The following is a description of a gene set: Mouse Gene Set: GOBP_EPOXYGENASE_P450_PATHWAY studied in species Mus musculus The chemical reactions and pathways by which arachidonic acid is converted to other compounds including epoxyeicosatrienoic acids and dihydroxyeicosatrienoic acids., and this is the list of marker genes: Cyp2b10, Cyp2j5, Cyp2a22, Cyp2a12 (cytochrome P450, family 2, subfamily a, polypeptide 12), Cyp2g1, Cyp2b9, Cyp2t4, Cyp4a31, Cyp2j8, Cyp2j6, Cyp2b13, Cyp2c23, Cyp2e1, Cyp4a32 (NCBI Gene Id 674313), Cyp2s1, Cyp2j7, Cyp4a10, Cyp2j11, Cyp2j9, Cyp2f2, Cyp2b19, Cyp2a4 (NCBI Gene Id 13086), Cyp2a5, Cyp2b23, Cyp2j13, Cyp2j12